Given this list of marker genes Phka1, Gsap, Zfp385c, Nat8f1, Kcnt1, Ptprm (protein tyrosine phosphatase receptor type M), Nek2, Arhgef37, Lrch1, Cnksr3, Lhx5, Prex2, Paqr6, Zfp521, Rnf182, Gabra6, Amot, Pepd, Pkp3, Etv4, Slc9a3, Arap1, Sebox (NCBI Gene Id 18292), Crtam, Dnajc3, Col18a1, Chd7, Car7, Icmt, Afap1l2, Hepacam, Gpr63, Fam107a (NCBI Gene Id 268709), Tmem41a, Cep72, Casq2, Tmem266, Npr1, Trim62, Tnc, Pdp2, Zfhx2os, Nhlh1, Mtcl2, Gdf10, Il16, Lig1, Traf6, H6pd, Fez2, Slc66a2, Gng13, 2410137M14Rik, En2, Prl2c2, Arhgap5, Hbegf, Cbln3, Zic2, Kank2, Dmd, Lhx1, Rif1, Ntn1, Fbxo24, Kit, Selenos (NCBI Gene Id 97368), Gm4425, Exph5, Plxdc1 (NCBI Gene Id 72324), Syne2, Tst (NCBI Gene Id 22117), Rhod, Tjp2, Btg1 (BTG anti-proliferation factor 1), Pcp2, Calb2, Dmrtc2, Zic1, Slc25a18, B3gnt5, Dhrs3, Erc1, Sytl3, Mmp24, Cmya5, Nkain4, Mcc, here is a description of the gene set: Molecular approaches to understanding the functional circuitry of the nervous system promise new insights into the relationship between genes, brain and behaviour. The cellular diversity of the brain necessitates a cellular resolution approach towards understanding the functional genomics of the nervous system. We describe here an anatomically comprehensive digital atlas containing the expression patterns of approximately genes in the adult mouse brain. Data were generated using automated high-throughput procedures for in situ hybridization and data acquisition, and are publicly accessible online. Newly developed image-based informatics tools allow global genome-scale structural analysis and cross-correlation, as well as identification of regionally enriched genes. Unbiased fine-resolution analysis has identified highly specific cellular markers as well as extensive evidence of cellular heterogeneity not evident in classical neuroanatomical atlases. This highly standardized atlas provides an open, primary data resource for a wide variety of further studies concerning brain organization and function. Top 100 ranked genes most specific to the cerebellum region of adult mouse brain. Mouse Gene Set: LEIN_CEREBELLUM_MARKERS from publication Lein ES, Hawrylycz MJ, Ao N, Ayres M, Bensinger A, Bernard A, Boe AF, Boguski MS, Brockway KS, Byrnes EJ, Chen L, Chen L, Chen TM, Chin MC, Chong J, Crook BE, Czaplinska A, Dang CN, Datta S, Dee NR, Desaki AL, Desta T, Diep E, Dolbeare TA, Donelan MJ, Dong HW, Dougherty JG, Duncan BJ, Ebbert AJ, Eichele G, Estin LK, Faber C, Facer BA, Fields R, Fischer SR, Fliss TP, Frensley C, Gates SN, Glattfelder KJ, Halverson KR, Hart MR, Hohmann JG, Howell MP, Jeung DP, Johnson RA, Karr PT, Kawal R, Kidney JM, Knapik RH, Kuan CL, Lake JH, Laramee AR, Larsen KD, Lau C, Lemon TA, Liang AJ, Liu Y, Luong LT, Michaels J, Morgan JJ, Morgan RJ, Mortrud MT, Mosqueda NF, Ng LL, Ng R, Orta GJ, Overly CC, Pak TH, Parry SE, Pathak SD, Pearson OC, Puchalski RB, Riley ZL, Rockett HR, Rowland SA, Royall JJ, Ruiz MJ, Sarno NR, Schaffnit K, Shapovalova NV, Sivisay T, Slaughterbeck CR, Smith SC, Smith KA, Smith BI, Sodt AJ, Stewart NN, Stumpf KR, Sunkin SM, Sutram M, Tam A, Teemer CD, Thaller C, Thompson CL, Varnam LR, Visel A, Whitlock RM, Wohnoutka PE, Wolkey CK, Wong VY, Wood M, Yaylaoglu MB, Young RC, Youngstrom BL, Yuan XF, Zhang B, Zwingman TA, Jones AR (PMID 17151600) species: Mus musculus